The following is a description of a gene set: studied in species Mus musculus Mouse Gene Set: GOBP_MEMORY The activities involved in the mental information processing system that receives (registers), modifies, stores, and retrieves informational stimuli. The main stages involved in the formation and retrieval of memory are encoding (processing of received information by acquisition), storage (building a permanent record of received information as a result of consolidation) and retrieval (calling back the stored information and use it in a suitable way to execute a given task)., and this is the list of marker genes: Syt4, Map1a, Crebbp, Ccnd2, Adcy1, Grin2b, Hrh2, Neto1, Ptchd1 (NCBI Gene Id 211612), Cpeb3, Prkcz, Bace1, Cux2, Mtor, Aph1c, Spg11 (NCBI Gene Id 98786), Nfix, Idua, Drd4, Chrna7, Sorcs3, Igf2, Ptgs2, Kcnq2, Comt, Mecp2, Gabrb3, Atp1a3, Btbd9, Kctd16, Calb1, Lgmn, Rps6kb1, Adgrf1, Atxn1, Camk4, Kat2b, Reln, Paip2, Cnr1, Grin2a, Crtc1, Rcan2, Slc1a1, Chrnb2, Ttc36, Slc24a2, Shank3, Snap25, Kalrn, Serpinf1, Pde4d, Eif4ebp2, Ptgs1, Bloc1s6, Nrg1, Pdcd10, Csmd1, Trpm7, Syt11, Gria1, Ldlr, Mdk (NCBI Gene Id 17242), Rin1, Plk2, Tafa2, Pde5a, Kat2a, Rogdi, Drd1, Ppp1r1b (NCBI Gene Id 217160), Itga5, Lmx1a, Crhr1, Foxo6, Itga8, Mapt, Scn2a, Glud1, Jph3, Rgs14, Ehmt2, Hrh3, S100b, Musk, Pja2, Pak6, Igf1, B4galt2, Ythdf1, Klk8, Pten, Eif2ak4, Ntrk2, Ulk4, Cyp7b1, Fgf13, Psen1, Itpr3, Slc6a4, Nfatc4, Pla2g6, Trpm4, Large1, Slc17a7, Shank1, Il1rn, Creb1, Casp1, Aph1b, Lrrn4, Htr2a, Rcan1, Glp1r, Slc8a3, App, Dcaf11, Npas4 (NCBI Gene Id 225872), Tac1, Dtnbp1, Nog, Kcnk2, Drd2, Acss2, Fos, Ngf, Trem2, Slc8a2, Itga3, Slc6a1, Lcn2, Tacr1, Fen1, Arc, Asic1, Lmx1b, Brinp1, Gm527, Il1b, Chst10, Psen2, Abca7, Srf, Adnp, Adcy8, Pak5, Grin1, Cck, Dbh, Oxtr, Plcb1, Chat, Apoe, Mme, Pgrmc1, Tuba1a, Shisa7 (shisa family member 7), Cx3cr1, Htr7, Camk2n1, Abcc1, Adrb1, Ntf5, Th, Oxt, Slitrk4, Shank2, Vps13b, Ntan1, Cic, Sgk1, Egr1, Atad1, Grm7, Slc2a4, Abcc8, Hrh1, Ptn, Gip, Atxn1l, Ctns